The following is a description of a gene set: Neuronal degeneration in the cerebellum, pontine nuclei, and inferior olivary nucleus. studied in species Homo sapiens Human Gene Set: HP_OLIVOPONTOCEREBELLAR_ATROPHY Olivopontocerebellar atrophy, and this is the list of marker genes: ATXN2, ATXN1, ERCC6, COQ2, ATXN7, MBTPS2, TTC19